Given this list of marker genes TRBV10-3, TRBV5-3, TRBV15, TRBV19 (NCBI Gene Id 28568), TRBV14, TRBJ2-1, TRBV20-1, here is a description of the gene set: Human Gene Set: QI_NAIVE_T_CELL_ZOSTAVAX_AGE_52_75YO_CD4_T_CELL_VS_NAIVE_CD4_T_CELL_7_TO_9DY_DN from publication Qi Q, Cavanagh MM, Le Saux S, NamKoong H, Kim C, Turgano E, Liu Y, Wang C, Mackey S, Swan GE, Dekker CL, Olshen RA, Boyd SD, Weyand CM, Tian L, Goronzy JJ (PMID 27030598) Genes down-regulated in naive T cell CD4-positive T cell vs naive CD4-positive T cell in seniors (52-75) after exposure to Zostavax, time point 7 to 9D. Comment: Table S3. BV and BJ gene segment usage in VZV-reactive CD4 T cells compared to naive and memory CD4 T cells (FDR <= 0.1). studied in species Homo sapiens Diversity and size of the antigen-specific T cell receptor (TCR) repertoire are two critical determinants for successful control of chronic infection. Varicella zoster virus (VZV) that establishes latency during childhood can escape control mechanisms, in particular with increasing age. We examined the TCR diversity of VZV-reactive CD4 T cells in individuals older than 50 years by studying three identical twin pairs and three unrelated individuals before and after vaccination with live attenuated VZV. Although all individuals had a small number of dominant T cell clones, the breadth of the VZV-specific repertoire differed markedly. A genetic influence was seen for the sharing of individual TCR sequences from antigen-reactive cells but not for repertoire richness or the selection of dominant clones. VZV vaccination favored the expansion of infrequent VZV antigen-reactive TCRs, including those from naive T cells with lesser boosting of dominant T cell clones. Thus, vaccination does not reinforce the in vivo selection that occurred during chronic infection but leads to a diversification of the VZV-reactive T cell repertoire. However, a single-booster immunization seems insufficient to establish new clonal dominance. Our results suggest that repertoire analysis of antigen-specific TCRs can be an important readout to assess whether a vaccination was able to generate memory cells in clonal sizes that are necessary for immune protection.